The following is a description of a gene set: from publication Motenko H, Neuhauser SB, O'Keefe M, Richardson JE (PMID 26092688) Mouse genes annotated to increased skin squamous cell carcinoma incidence (MP:0009704) retrieved from the Mouse Genome Informatics database via MouseMine studied in species Mus musculus Mouse Gene Set: MP_INCREASED_SKIN_SQUAMOUS_CELL_CARCINOMA_INCIDENCE, and this is the list of marker genes: Perp, Pten (NCBI Gene Id 70161), Trp53, Snai1, Otulin (OTU deubiquitinase with linear linkage specificity), Fyn, Rint1, Grhl3, Chuk, Xpa, Terf2